Given this list of marker genes Akt1, G6pd2, Adcy10 (adenylate cyclase 10), Mfn2, Stat3, Ins1, Acp5, Park7, Ppara, Prkn, Abcb7, Mmp3, Sirt2, Trp53, Birc3, Hbp1, Mycn, Cryab, Abcd2, Fyn, Mpv17l, Sirt1, Sirt5, Ndufc2, Map3k7, Ins2, Plin5, Sirt3, Mt3, Brca1, Coa8, Abcd1, Pax2 (paired box 2), Esr2, Hk2, Ptgr1 (NCBI Gene Id 67103), Tigar, Trim30a, G6pdx, Hif1a, Hspd1, Cflar, Vdac1, Pink1 (NCBI Gene Id 68943), Crp, Ctns, Bcr, Ptger4, Rhoa, Tfap2a, Pon3, here is a description of the gene set: Mouse Gene Set: GOBP_NEGATIVE_REGULATION_OF_REACTIVE_OXYGEN_SPECIES_METABOLIC_PROCESS Any process that stops, prevents or reduces the frequency, rate or extent of reactive oxygen species metabolic process. studied in species Mus musculus